The following is a description of a gene set: Yersinia YopH to TCR-NFAT signaling pathway. Pathway ID: N01108. Pathway type: Pathogen. Pathway class: nt06528 Calcium signaling. Human Gene Set: KEGG_MEDICUS_PATHOGEN_YERSINIA_YOPH_TO_TCR_NFAT_SIGNALING_PATHWAY Pathway Definition from KEGG: YopH -| (SLP76,LAT,VAV) species: Homo sapiens, and this is the list of marker genes: VAV2, LAT, LCP2, VAV1, VAV3